Given this list of marker genes Osr1, Stat1, Wnt4, Six2, Pax2, Tcf21, Amer1, here is a description of the gene set: The process in which relatively unspecialized cells acquire specialized structural and/or functional features that characterize the mesenchymal cells of the kidney as it progresses from its formation to the mature state. Mouse Gene Set: GOBP_MESENCHYMAL_CELL_DIFFERENTIATION_INVOLVED_IN_KIDNEY_DEVELOPMENT species: Mus musculus